The following is a description of a gene set: Human Gene Set: GOBP_EXIT_FROM_MITOSIS studied in species Homo sapiens The cell cycle transition where a cell leaves M phase and enters a new G1 phase. M phase is the part of the mitotic cell cycle during which mitosis and cytokinesis take place., and this is the list of marker genes: CLASP1, UBE2S, CDC14B, CHMP2A, NFIA, SIRT2, RGCC, CDC23, NFIB, CDKN1C, KNTC1, BIRC5, TGFB1, CDCA5, RPL24, CDC14A, CLASP2, UBE2C (ubiquitin conjugating enzyme E2 C), CDKN1B, NEUROG1, PPP1R9B, CDC14C, MAD2L1BP, PPP2R2D, ZW10, NPM2, EPS8, ANLN, CTDP1, CHMP4B, CHMP7, SPAST